Given this list of marker genes CYP27A1, here is a description of the gene set: Reactome Pathway: Defective CYP27A1 causes CTX part of: Metabolic disorders of biological oxidation enzymes CYP27A1, a mitochondrial matrix sterol hydroxylase, catalyses the 27-hydroxylation of side-chains of sterol intermediates. In the bile acid synthesis pathway, CYP27A1 catalyses the first step in the oxidation of the side chain of sterol intermediates such as cholestane-triols. Defects in CYP27A1 can cause Cerebrotendinous xanthomatosis (CTX; MIM:213700), a rare sterol storage disorder. Decreased bile acid production results in the accumulation of sterol intermediates in many tissues, including brain. The disorder is characterised by progressive neurologic dysfunction, premature atherosclerosis and cataracts. <br> species: Homo sapiens